Given this list of marker genes Atp6v1a, Egfr, Polr2e, Muc20, Mapk7, Erbin, Ptprj, Rac1, Ntrk3, Sh2b2, Rhoa, Atp6v0d1, Col5a3, Col3a1, Gipc1 (NCBI Gene Id 67903), Pdgfa, Col6a2, Pik3cb, Ltk, Vegfb, Tlr9, Thbs1, Dusp4, Polr2k, Itch, Itga3, Atp6v1g3, Cbl, Grb2, Rap1a, Nck1, Ptpru, Polr2b, Fgf16, Ntf3, Flt1, Akt3, Thbs2, Atp6v0e2, Ptpn6, Stat5b, Ncbp2, Ralgds, Rnf41, Aph1b, Fgf15, Grb10, Tcirg1, Grap2, Lrig1, Shc2, Ptprk, Atp6ap1, Epgn, Vrk3, Atp6v1c1, Pcsk6, Atp6v0a4, Atp6v1d, Pik3c3, Mmp9, Gab1, Fgf5, Crkl, Creb1, Itgb3, Mapk1, Fn1 (fibronectin 1), Pgf, Sh3gl3, Csk, Calm3, Ptpn18, Pdgfra, Src, Calm2, Prkcb, Ubb, Plat, Furin, Fgf2, Kdr, Gga3, Rps6ka1, Stat3, Vav1, Vegfa, Memo1, Uba52rt, Fam83b, Cltc, Sh3gl1, Akt1, Pik3r4, Cdc37, Sh2b3, Polr2i, Fgf8, Rictor, Irs2, Gtf2f2, Nrg3, Col9a1, Mapkapk3, Rapgef1, Erbb4, Ptk6, Ap2m1, Pak1, Fgf3, Erbb3 (NCBI Gene Id 97627), Cdh5, Pxn, Ntrk1, Areg, Fgf22, Pik3r1, Ncf4, Lama4, Rap1b, Actb, Kidins220, Uba52, Ppp2r1a, Rps6ka2, Col1a2, Fgf17, Thbs4, Rab4b, Cybb, Ap2s1, Fgfrl1, Pag1, Fgf1, Ptpn3, Grb7, Mapk13, Eps15, Dnal4, Pik3ca, Stub1, Atp6v1e2, Ereg, Cyba, Sh2d2a, Col11a1, Nrp2, Rps6ka3, Atp6v0c, Akt2, Ntrk2, Atf1, Irs4, Polr2h, Col4a5, Frs3, Kitl, Rps27a (NCBI Gene Id 78294), Ctnnd1, Egr2, Plcg1 (phospholipase C, gamma 1), Tgfbr3, Aamp, Col9a3 (collagen, type IX, alpha 3), Sh3kbp1 (NCBI Gene Id 80469), Plg, Rps6ka5, Col6a6, Polr2f, Atp6v1e1, Mapk11, Pik3r2, Nrg1, Abi1 (abl interactor 1), Nckap1l, Prkcd, Col6a1, Atp6v1b1 (NCBI Gene Id 269766), Ppp2cb, Dusp6, Baiap2, Actg1, Fgf4, Vav2, Arf6, Atp6v0e, Dusp7, Kras, Alkal1, Elmo2, Ptk2b, Polr2a, Ppp2r1b, Ptpn11, Mst1, Thbs3, Atp6v1h, Nrp1, Pdgfb, Ppp2ca, Map2k2, Nck2, Stat6, Tns3, Galnt3, Stam2 (NCBI Gene Id 99454), Trib3, Stam, Hbegf, Tnk2, Fgf6, Epn1, Mknk1, Yap1, Pdgfd, Fam83d, Erbb2, Fam83a, Ap2a1, Spint2, Them4, Stat5a, Fgf9, Wasf2, Polr2l, Ep300, Pdgfrb, Mapk3, Gtf2f1, Ntf5, Atp6v1g1, Usp8, Pak3, Ap2b1, Hgs, Shc3, Itga2, Col5a1, Flrt3, Atp6v1c2, Atp6v0d2, Atp6v0b, Bcar1, Vegfd, Spint1, Ptprz1, Ctsd, Psenen, Nos3, Spred1 (NCBI Gene Id 99293), Spry1, Col6a5, Grap, Col9a2 (NCBI Gene Id 12840), Igf1, Fer, Tns4, Flt3l, Lck, Ranbp9, Ncbp1, Prkacb, Dock1, Nedd4, Fyn, Aph1a, Ptbp1, Prkce (protein kinase C, epsilon), Alkal2, Fgfr3, Srf, Tgfa, Ptpn2, Eps15l1, Fgfbp3, Cilp, Mtor, Esr1, Cyfip1, Ranbp10, Map2k1, Wasf3, Btc, Axl, Mlst8, Shc1, Pak2, Diaph1, Clta, Ptk2, Psen1, Ide, Braf, Hnrnpa1, Col4a2, Ins1, Fgfbp1, Hspb1, Flrt1, Mapkap1, Atp6v1g2, Mst1r, Fgf7, Sos1, Spp1, Spry2, Itgav, Chek1, Dock7, Ptprf, Ptpn12, Egf, Ap2a2, Fgfr4, Kl, Rock2, Flt4, Wwox, Cav1, Mapk14, Jak2, Igf2, Brk1, Vav3, Pik3r3, Vegfc, Mapkapk2, Arhgef7, Cma1, Megf6, Hdac3, Ywhab, Sh3gl2, Wwp1, Rasa1, Hpn, Dusp3 (dual specificity phosphatase 3 (vaccinia virus phosphatase VH1-related)), Yes1, Col5a2, Alk, Fgf23, Igf1r (NCBI Gene Id 77773), Nckap1 (NCK-associated protein 1), Ngf, Lyn, Klb, Mdk, Shb, Col4a1, Abi2, Atp6v1b2, Fgf20, Frs2 (fibroblast growth factor receptor substrate 2), Matk, Ptn, Hdac1, Rock1, Ctnnb1, Nab2, Col2a1, Calm1, Polr2c, Jup, Col11a2, Fgfr1, Ptpn1, Sphk1, Prkaca, Hgfac, Elmo1, Prkcz, Hsp90aa1, Fgf18, Wasf1, Spred2 (NCBI Gene Id 97717), Crk, Col4a3, Bdnf, Polr2g, Cdc42, Mapk12, Pdgfc, Fes, Fgf10, Ubc, Itgb1, Rab4a, Ncf2, Hras, Ctnna1, Chd4, Atp6v0a2, Polr2d, Ncstn, Pcsk5, Hgf, Atp6v0a1 (NCBI Gene Id 11975), Kit, Flrt2, Sgk1, Col6a3, Col1a1, Ppp2r5d, Cyfip2, Atp6v1f, Pdpk1, Ncf1, Met, Prr5, Insr, Col4a4, here is a description of the gene set: Signaling by Receptor Tyrosine Kinases studied in species Mus musculus Mouse Gene Set: REACTOME_SIGNALING_BY_RECEPTOR_TYROSINE_KINASES